The following is a description of a gene set: studied in species Homo sapiens Human Gene Set: GOBP_CMP_N_ACETYLNEURAMINATE_BIOSYNTHETIC_PROCESS The chemical reactions and pathways resulting in the formation of CMP-N-acetylneuraminate, a substance composed of 5-(acetylamino)-3,5-dideoxy-D-glycero-D-galacto-non-3-ulosonic acid in glycosidic linkage with cytidine monophosphate., and this is the list of marker genes: GNE, SLC35A1, NANS (N-acetylneuraminate synthase), CMAS, NANP